The following is a description of a gene set: Human Gene Set: GOCC_HISTONE_METHYLTRANSFERASE_COMPLEX species: Homo sapiens A multimeric complex that is able to catalyze the addition of methyl groups to histone proteins., and this is the list of marker genes: HCFC2, KMT2B, RCOR1, SETD1B, PRDM4, NCOA6, KMT2D, SIRT1, TAF6, ZNF335, ASH2L, MTF2, HDAC2, EPOP, PRMT5, EZH1, PAGR1, CXXC1, EZH2, C17orf49, RUVBL1, RBBP7, MEN1, KAT8, RBBP5, KDM6B, KMT2C, RBBP4, SETD1A, MCRS1, DYDC1, PAXIP1, LAS1L, TAF9, HDAC9, DPY30, TAF7, WDR5B, PHF19, PELP1, TRIM37, JARID2, E2F6, TAF1, EED, WDR82, KDM6A, RUVBL2, HCFC1, RNF2, KDM1A, CHD8, TAF4, BOD1, MAX, WDR5, PRPF31, INO80C, BOD1L1, KMT2A, MGA, PHF20, TEX10, UTY, DYDC2, KANSL1, AEBP2, PHF1, CBX5, SUZ12, DNMT3L, SENP3